Given this list of marker genes UVSSA, GTF2B, TCERG1L, SCAF4, RRN3, SMYD3, RPRD2, ANP32B, NEDD4 (NCBI Gene Id 4734), CCNT2, ELP2, PCF11, NCOA3, TCERG1, BRCA1, YTHDC2, RTRAF, POLR2M, SPTY2D1, LEO1, PPIB, RPAP2, RPRD1A, URI1, ERCC6, HNRNPU, CCNT1, AGO1 (NCBI Gene Id 26523), MAF1, TAF10, WAC, PHRF1 (NCBI Gene Id 57661), PCIF1, ERBB2, ZNF326, DHX9, CDC73, SMYD2, ZFP36, RECQL5, WDR43, RRN3P2, ESRRB (NCBI Gene Id 246148), CCAR2, SUPT4H1, AGO2, PAF1, SCAF8, STOM, ELOF1 (elongation factor 1), PABPN1, ERCC5, CTR9, PKN2, BRD4, BIN1, RPRD1B, SCAF1, here is a description of the gene set: Human Gene Set: GOMF_RNA_POLYMERASE_BINDING studied in species Homo sapiens Binding to an RNA polymerase molecule or complex.